Given this list of marker genes GARS1, NUDT3, NUDT10, FHIT, NUDT11, NUDT4B, NUDT4, KARS1, here is a description of the gene set: Human Gene Set: GOBP_DIADENOSINE_POLYPHOSPHATE_METABOLIC_PROCESS The chemical reactions and pathways involving diadenosine polyphosphate, a derivative of the nucleoside adenosine with phosphate groups attached. species: Homo sapiens